Given this list of marker genes PPFIA2, CDC42, CASQ1, CCK (NCBI Gene Id 885), NDRG2, TMEM144, PDE6D, CUTC, MRPL49, DHRS9, ACSL4, NSL1, MAGEH1, GRM3, TSNAX, CPNE6, ROGDI, MSRB2, PRPSAP2, AGTPBP1, KCNJ3, EVI2A, USP33, SGK3, GNAI1, LYRM1, FEZF2, SAR1A, ANXA7, SPAST, ATP5MG, PGBD5, ANKS1B, BEST1, PEX19, GABARAPL2, FHIT, CRYL1, CYTH1, BCAS1, ANXA3, NDUFS3, MAT2B, CCDC121, VIP, AKR7A3, TTC1, REPS2, GRM1, ZSCAN31, CRYM, PLCL1, MMD, TCEAL1, SH3GL2, SLC30A10, CALM2, ACYP2, ARRB1, MYBPC1, CLCA4, YPEL5, CRYZL1, TTPA, SLCO1A2 (solute carrier organic anion transporter family member 1A2), THTPA, EDIL3, NANOS1, RERGL, FXYD1, ATP5PB, RND1, TCEAL2, SLC16A7, POPDC3, CYRIB, HPCA, SELENOW, SERPINI1, GPR22, ENPP4, CDR1, MGST3, HPRT1, SNX11, BASP1 (brain abundant membrane attached signal protein 1), COX5B, MORF4L2, FBXO3, MBP, EPB41L3, SCHIP1, LYRM9, GUK1, SNCG, ENPP2, KCNK1, CHN1, DYNC1I1, PPP1R1A, S1PR1, PARP8 (poly(ADP-ribose) polymerase family member 8), TPM3, SHTN1, SELENOP, PPA1, UROS, CAMK2G, CRBN, SH3GL3, NTSR2, PPP2R5A, ATRNL1, UGT8 (NCBI Gene Id 7368), ETNPPL, IMPA1, SLC31A2, MDH1, ADD3, ORC4, SIRT5, GABRB2, PEX11B, ANKRD46, FUT9, VSX1, CA4, HPCAL4, here is a description of the gene set: Human Gene Set: VERHAAK_GLIOBLASTOMA_NEURAL studied in species Homo sapiens Genes correlated with neural type of glioblastoma multiforme tumors. from publication Verhaak RG, Hoadley KA, Purdom E, Wang V, Qi Y, Wilkerson MD, Miller CR, Ding L, Golub T, Mesirov JP, Alexe G, Lawrence M, O'Kelly M, Tamayo P, Weir BA, Gabriel S, Winckler W, Gupta S, Jakkula L, Feiler HS, Hodgson JG, James CD, Sarkaria JN, Brennan C, Kahn A, Spellman PT, Wilson RK, Speed TP, Gray JW, Meyerson M, Getz G, Perou CM, Hayes DN, Cancer Genome Atlas Research Network (PMID 20129251) The Cancer Genome Atlas Network recently cataloged recurrent genomic abnormalities in glioblastoma multiforme (GBM). We describe a robust gene expression-based molecular classification of GBM into Proneural, Neural, Classical, and Mesenchymal subtypes and integrate multidimensional genomic data to establish patterns of somatic mutations and DNA copy number. Aberrations and gene expression of EGFR, NF1, and PDGFRA/IDH1 each define the Classical, Mesenchymal, and Proneural subtypes, respectively. Gene signatures of normal brain cell types show a strong relationship between subtypes and different neural lineages. Additionally, response to aggressive therapy differs by subtype, with the greatest benefit in the Classical subtype and no benefit in the Proneural subtype. We provide a framework that unifies transcriptomic and genomic dimensions for GBM molecular stratification with important implications for future studies.